Given this list of marker genes Bdnf, Rapgef2, Cd2ap, Ntf5, Rap1a, Ngf, Rapgef1, Kidins220, Ntrk1, Magi2, Ntf3 (neurotrophin 3), Sort1, Coro1a, Shoc2, here is a description of the gene set: Mouse Gene Set: GOBP_NERVE_GROWTH_FACTOR_SIGNALING_PATHWAY The series of molecular signals initiated by nerve growth factor (NGF) binding to its receptor on the surface of a target cell, and ending with the regulation of a downstream cellular process, e.g. transcription. species: Mus musculus